The following is a description of a gene set: The c-Jun N-terminal kinases (JNKs) are encoded by three genes that yield 10 isoforms through alternative mRNA splicing. The roles of each JNK isoform in the many putative biological responses where the JNK pathway is activated are still unclear. To examine the cellular responses mediated by different JNK isoforms, gain-of-function JNK1 polypeptides were generated by fusing the upstream mitogen-activated protein kinase kinase, MKK7, with p46JNK1alpha or p46JNK1beta. The MKK7-JNK fusion proteins, which exhibited constitutive activity in 293T cells, were stably expressed in Swiss 3T3 fibroblasts using retrovirus-mediated gene transfer. Swiss 3T3 cells expressing either of the MKK7-JNK polypeptides were equally sensitized to induction of cell death following serum withdrawal. To search for other cellular responses that may be selectively regulated by the JNK1 isoforms, the gene expression profiles of Swiss 3T3 cells expressing MKK7-JNK1alpha or MKK7-JNK1beta were compared with empty vector-transfected control cells. Affymetrix Genechips identified genes for which expression was increased in MKK7-JNK-expressing cells relative to vector control cells. Twenty genes including those for c-Jun, MKP-7, interluekin-1 receptor family member ST2L/ST2, and c-Jun-binding protein were induced similarly by MKK7-JNK1alpha and MKK7-JNK1beta proteins, whereas genes were selectively increased by MKK7-JNK1alpha and genes were selectively increased by MKK7-JNK1beta. The set of genes selectively induced by MKK7-JNK1beta included a number of known interferon-stimulated genes (ISG12, ISG15, IGTP, and GTPI). Consistent with these gene expression changes, Swiss 3T3 cells expressing MKK7-JNK1beta exhibited increased resistance to vesicular stomatitis virus-induced cell death. These findings reveal evidence for JNK isoform-selective gene regulation and support a role for distinct JNK isoforms in specific cellular responses. from publication Han SY, Kim SH, Heasley LE (PMID 12354774) Human Gene Set: HAN_JNK_SINGALING_DN studied in species Mus musculus Genes down-regulated in 3T3 cells (fibroblast) upon activation of JNK pathway., and this is the list of marker genes: FAS, TAF1D, MAP4K3, LCN2, ERO1A, COL6A1, CCL15, LBP, GHR, AHR, SEMA3C, SOD3, ABCA1, ISYNA1, CD9, RBP1, SLC10A6, SPIB, SOCS3, PLTP, CD74, LIFR (LIF receptor subunit alpha), SLC29A1, WNT6 (Wnt family member 6), OGN, IGFBP4, ANXA8L1, ENPP2, GDF10, HSD11B1, CYP2F1 (cytochrome P450 family 2 subfamily F member 1), C3, RGS2, CP, HAS2, COL6A2, IFITM1, PFKP, CD14